Given this list of marker genes Slc6a11, Nherf1, Slc7a14, Slc6a13, Slc6a8, Slc6a1, Slc32a1, Slc6a12, Slc6a6, here is a description of the gene set: Mouse Gene Set: GOMF_GAMMA_AMINOBUTYRIC_ACID_TRANSMEMBRANE_TRANSPORTER_ACTIVITY Enables the transfer of gamma-aminobutyric acid from one side of a membrane to the other. Gamma-aminobutyric acid is 4-aminobutyrate (GABA). studied in species Mus musculus